The following is a description of a gene set: Genes having at least one occurrence of the motif NNNCGGCCATCTTGNCTSNW in the regions spanning 4 kb centered on their transcription starting sites. This matches the YY1 transcription factor binding site V$YY1_02 (v7.4 TRANSFAC). species: Homo sapiens Human Gene Set: YY1_02, and this is the list of marker genes: CNPY4, INO80D (NCBI Gene Id 54891), PBX3, FAM222B, EXT1, FOXO3, SELENOT (NCBI Gene Id 51714), ZFAT, SCRN1, ARF1, CCDC186, LYPLA2, NCDN, ZC3H11A, UBXN11, PUM1, CERT1, ZFP37, ATE1 (NCBI Gene Id 11101), ST20-AS1 (ST20 antisense RNA 1), SLITRK5, UBL3, KIF15 (NCBI Gene Id 56992), MGAT4C, ZIC3, ABCE1, DHX15, KMT2E, RALA (NCBI Gene Id 5898), UBR5, PSMD8, DAP3 (NCBI Gene Id 7818), ZBTB22, FBXO9, PPP1R12B, ABHD1, RASL11B, PCBP4, ZFX, NDRG3, ZNF638, NACA, SPCS2 (signal peptidase complex subunit 2), TSC1, IER2, MRPL49, ZZEF1, SEPTIN7, CLVS1, RUFY1, ENSA, RBM15B, OSBPL11, STRN4, TBC1D14, SMYD5 (NCBI Gene Id 10322), TAF6, ASXL2, PRKCSH, NASP, PCIF1, TFAP4 (transcription factor AP-4), CTCF, POLK, RAD21, FBXL19-AS1, HOXA2, MARK3, FZD8, PATZ1, DDX6, EPC1, ODAD3, GAPDH, C19orf48P, IWS1, MTMR2, AP1G1, FAM120C (NCBI Gene Id 54954), CSDE1, GLG1, BAD, NTRK3, SERBP1, DEPTOR, ZNF524 (zinc finger protein 524), RPL30, PPP2CA, TIA1, DENND4A, NAT8L, PRRC2C, KIAA1143, CNNM1, PEG3, MIOS, DGCR2, TRA2B, SRSF3, TET2, PYY2, ADO, FIZ1, EP300, SART3, ANAPC10, TOP3A, SMCR8, PIGL, JTB (NCBI Gene Id 23561), HSPA8, RAB1B, KDM6A, LSM14A, RASGRP2, RBM39, GPATCH4, NCOR1, CHTOP, RAB1A, RABL6, CHCHD10, BCL2L1, LUC7L3, DEAF1, B3GALT6, CCDC71, POU2F1, CCNK, NUDT3, HMGXB4, EXOC6, PCF11, CCND1, C21orf58, BCL11B, GTF3C2, KERA, ATP5PB, C9orf163, TOMM40L, GNAO1, STX10, PHC3 (polyhomeotic homolog 3), FKRP, N4BP2L2, UBTF, PRPF38B, ADNP, SNRNP35, SHKBP1, YY1AP1 (YY1 associated protein 1), TAPT1, WSB1, TUBA1A, AIP, THAP1, AP4S1, FASTK, SYNGR1, NFYC, TCF4, EFCAB2, SELENOM, CYB5D2, AP3D1, FUT10, TMEM187, UBE2J2, CHD4, MAP3K4, TMEM80, ZNF207, DNAJC22, ODF2, ZBTB40, USF1 (upstream transcription factor 1), FNDC7, ENOX1, MRPL1, VEZF1, MAEA, WASL, RIF1, ZNF689, ACTR8, PTBP2, TNKS2, ARCN1, FAM193B, AKT1S1, TPGS2, EEF2, CDKN2C, EIF4G1, UBA52, CAMLG, DYRK1B, DZIP1, GTF2A1, REXO1, BTF3, RNF26, KLF7, ZIM2, H1-0, PRDM10, ZFY (NCBI Gene Id 7544), ISCU, PIGV, WDR77, MORF4L2, TBC1D17, ERH, ADK, MECOM, MYNN, ASB2, MTFP1, TAPT1-AS1, SNX13, RBM26, PIAS3, RAB10, YWHAE, BCL2L13, ARID4A, E2F6, POLR3E, RPL35A, HIC2, ASH1L, GIGYF2, STRN3, SNAP25, MPDU1, RPRD2, VASP, TUG1, CSAD, BRSK2, KDM2A, SLC39A9, ZZZ3, GBF1, MGAT4B, CNOT3, UPF3B, PCNT (pericentrin), PYY, WDR13